The following is a description of a gene set: from publication Yamagata T, Benoist C, Mathis D (PMID 16623764) Human Gene Set: GSE3039_NKT_CELL_VS_ALPHABETA_CD8_TCELL_DN Genes down-regulated in NKT cell versus CD8A CD8B T cells. species: Homo sapiens Three innate (B1-B, NKT, CD8aaT cells) and adaptive (B2-B, CD4T, CD8abT cells) cell-types were sorted by FACS. Three biological replicates for NKT, CD4T, CD8aaT, CD8abT cells and two biological replicates for B1 and B2 cells were generated and the expression profiles were determined using Affymetrix Mu74Av2 chip. Comparisons between the sample groups allow the identification of genes differentially expressed between the innate and adaptive cell-types., and this is the list of marker genes: KPNA3, VPS29, PWP2, POLR1F, RASA3, IRF9, GYPC, ST8SIA4, RALGDS, MRPS31, GTPBP4, ENTPD1, CCDC88A, EPHX1 (epoxide hydrolase 1), PPCS, SGSH, DNAJA3, RNF180, AMMECR1L, LPP, AP3M2, PLS3, PATJ, LRP6, NFATC2, RTCB, MRAP, HERPUD1, TRAF3IP1, BTAF1, RNASEH1, DUSP19, IL13RA1, MIEN1, GNPNAT1, TMEM65, USP9X, SOAT1, CTNND2, ABCF1, SUB1, MTAP, SMCHD1, CTNNA1, SLC35B3, GCLC, TMEM192, SLC22A5, TOX2, OGFOD1, SNAP29, CREBL2, ALG9, SLC45A4, BEX3, PURA, SLC25A3, MAK16, NOP53, CD80, CDIP1, SERPINB6, GLT8D1, CSNK1A1 (NCBI Gene Id 55416), ITGA9 (NCBI Gene Id 3680), SH2D1B, ERP44, MRPS22, MAGED1, GORAB, EIF3J, U2SURP, DIPK2A, TRNAU1AP, CXCL10, ADH5, PRORP, RAB3IL1, ALKBH1, SLC39A1, EPRS1, PRXL2B, HES1, RGS12, PLEKHA3, STAB2, SRSF6, FTH1, TYK2, TMEM168, DPH5, SOD2, SELENOT, CCT8, ANPEP, ATF6, DYSF, ORC4, PLXDC2, KCNK6, TUT4 (terminal uridylyl transferase 4), RNF122, CSNK1G3, CCT4, DDRGK1, RAB12, PRKACB (NCBI Gene Id 5567), BMP2, CDC42BPB, IL7R (NCBI Gene Id 3575), CRTAP, CCR9, MRPL11, EVA1B, SMAD5, B4GALT4, RPL4, NATD1, NDUFC2, RTL5, TRMT5, ACBD5, EXT1, JMY, PANK1 (NCBI Gene Id 53354), WASHC4, CHD2, CYTH3, AKT3, NRBF2, CD7, SAMHD1, SCOC, SLC22A23, MTARC2, GTF2H2, MYCL, TOR3A, PHLPP2, GP2, ALG5, ISG15, ADAM23 (NCBI Gene Id 8745), ARHGAP17, EIF3A, MRPS33, ADCY3, PREB, ZNF229, DCAF13, THAP12, LFNG, SH3PXD2A, MAGT1 (NCBI Gene Id 84061), DCAF7, RNF138, TRMT13, SNAPC3, TIFAB, AASDH, GLS, MARF1, PPDPF, SCD, RTN1, TUBB2B, C2orf88, RIPK3, USP18, BMP2K, PLBD2, TNFRSF11A, PHC3, SLC4A7, GRK5 (G protein-coupled receptor kinase 5), ITGAL, GFER, POLR3H, RUNDC3B, ATXN1, YTHDF2, KLK8, KCTD6, FAM120B, CAPN2, RABEP2, ATP10D, RPF1, RPL36A, C1orf216, MITF, ARRDC3, DDX18, IGKC, CD79B, CD4, COMT, SAT1, IL6R, PWWP2A